The following is a description of a gene set: species: Mus musculus Mouse Gene Set: GOBP_NEGATIVE_REGULATION_OF_THYMOCYTE_APOPTOTIC_PROCESS Any process that stops, prevents, or reduces the frequency, rate or extent of thymocyte death by apoptotic process., and this is the list of marker genes: Bmp4, Jak3, Efna1, Rorc, Bcl11b, Vhl, Hif1a (NCBI Gene Id 15251), Rag1, Blm, Ada, Ptcra, Kifap3